The following is a description of a gene set: species: Homo sapiens The chemical reactions and pathways resulting in the breakdown of a phenol, any compound containing one or more hydroxyl groups directly attached to an aromatic carbon ring. Human Gene Set: GOBP_PHENOL_CONTAINING_COMPOUND_CATABOLIC_PROCESS, and this is the list of marker genes: MAOA, DIO3, DBH, DIO1 (iodothyronine deiodinase 1), COMT, FAH, MAOB, MOXD1, SLC6A3, SULT1A1 (sulfotransferase family 1A member 1), MOXD2P, PDE1B, SULT1A4, SULT1A3, DIO2